The following is a description of a gene set: Human Gene Set: ZNF146_TARGET_GENES studied in species Homo sapiens from publication Yevshin I, Sharipov R, Kolmykov S, Kondrakhin Y, Kolpakov F (PMID 30445619) Genes containing one or more binding sites for (ZNF146) in their promoter regions (TSS -1000,+100 bp) as identified by GTRD version 20.06 ChIP-seq harmonization., and this is the list of marker genes: AGK-DT (NCBI Gene Id 105375538), HTR5A, CCDC18, JPX, NSL1, FAM83C-AS1, ZNF609, CHURC1-FNTB, CCNE1, LINC01349, ZNF579, CHEK2, TOMM7, LINC01886, ATRIP, WRAP53, NME1, RANBP3, TMEM68, TBC1D13 (TBC1 domain family member 13), ITGB1, ITPK1P1, IFNAR1, PLK1, LARGE1 (LARGE xylosyl- and glucuronyltransferase 1), RNU1-52P, TRIAP1, MIR5188, TMEM79, EEF1A1P8, UBE2I (ubiquitin conjugating enzyme E2 I), MIS12, INTS5, RLIG1, TUBD1, ZNF101P1, RPP14, APRT, TSEN54, ALG1 (NCBI Gene Id 56052), VWA8-AS1, DNAJC27, FAM81B, TARS2, ST13P2, MTF2, STRBP, JMJD4, C17orf67, ABCD1, RNU7-24P, APLP2, NLRP5, RNA5SP60, MRPS2, RNVU1-19, CCDC74A, HMGB1, FADS2, ODF2L, MRPS31P5, ALKBH3, COX16, HNRNPA3P3, ZNHIT6, GPS1, CRYM, HSP90AB1, H4C8, YAP1, RPS4XP19, SERP1, SNX12, LINC02953, RPL9P28, ZNF529, RN7SL322P, NDUFB3, RBPMS, RN7SL19P, ZFYVE26, H2AC11, WDR11, KMT5B, GSPT1, MED18, PPP1R14BP5, MTBP, PHIP, PHF19, LINC00917, MRPL27, AURKAIP1, RASL11A, SMARCA1, SCRT1, DPH7, MAST3-AS1, ADGRB3, MT-ATP6, MRPS34, SIRT6, ARHGAP45, SMCO2, CCDC97, NOP56, IGLV4-60, PRPF8, RNU6-131P, ARHGEF2, ENSG00000259362, MCL1, VPS33A, ATP5MC2, TIA1, ZNF540, MTFR1P1, WEE2, SPICP1, GSAP, BORCS8, GSTCD (glutathione S-transferase C-terminal domain containing), ADGRL1, MIR1302-3, GIT1, NACA3P, PLCB2-AS1, PSMD9, RNU7-38P, SMG7-AS1, ASH2L, SEMA7A, AP1G1, CALM1, LTN1, FAM13A, TMEM223, GDI1, TMEM167B-DT, GUCD1, MEF2D, MRPL1 (mitochondrial ribosomal protein L1), HELQ, PGS1, UBP1, MT-RNR1, LIPM, NOP16, CFAP20, PLAGL1, C2orf42, TMCO1, SNAP25-AS1, CNNM1, CYB5D2, MFF-DT, STX16-NPEPL1, HIVEP3, FHL1, ENSG00000247416, PTS (6-pyruvoyltetrahydropterin synthase), SPSB2, HHATL, CLTCL1, ZMPSTE24-DT, BLOC1S1, GBA1, LMAN2, ADAM22, WDR11-DT, GALNT16-AS1, LINC01933, ADAP2, IZUMO4, LZIC, ZNF791, MT-TA (mitochondrially encoded tRNA-Ala (GCN)), TIPRL, ENSG00000232234, SLC3A1, GDI2, WNK3, RNU6-38P, YBEY, RNU6-232P, TCF3, OGFOD1, MRPL21, INTS12, LAMP2, ARPC3P3, CNIH3, TAX1BP1, SNX25P1, CALM1P1, HSPD1P21, TJP3, LINC01719, SNX29P2, RNU6-1059P, TTC3, MITD1, DSTYK, RANBP3-DT, STX18-AS1, ACTMAP, ANAPC2, DNMT3A, AGK, RFC1, PTPRN, RBBP5, MTHFD2L, BBS7, C10orf88, RNU5A-5P, SMPD4P1, ITFG2-AS1, RNU7-27P, DNTTIP1, PIERCE1, TRIM46, MALLP2, MT-ATP8, PGBD5, MACROH2A1, FAM136A, MDH1 (NCBI Gene Id 4190), SPINT1-AS1, RPL36AP18 (NCBI Gene Id 100271328), COX11P1, RYR1, TOP3B, STMP1, SELENOH, SSRP1, ZNF554, BMS1, RPL37, ZNF233, HDGF, C4BPAP2, DCUN1D2-AS, EME2, ZNF181, NOSIP, TSEN15, HERC1, RPS20, SBF2, TAFA2, EXOSC1, SLC33A1, IGDCC4 (immunoglobulin superfamily DCC subclass member 4), SNRNP35, MT-TE, RTTN, CDK1, NOL8, BBX, COPS9, RNU2-31P, ZNF335, TPRX1 (NCBI Gene Id 284355), TLK1, C12orf76, MT-TN, USPL1, CCNL1, TAOK3, CCDC159, CALCRL-AS1, IGHMBP2, CRTC3, LEO1, SCAMP5, HMG20A, SEC22C, FAM227B, SMARCD3, CMKLR1, KPNB1-DT, TSPAN10, ARID1B, COPS7B, RFNG, NOL12, HP1BP3, DCTN5, MIA2, NCAPG2, TM9SF4, ADIPOR1, ANKRD36BP1, AKT2 (NCBI Gene Id 208), PLAC8, EPCIP-AS1, MARCHF8, CCNB1IP1, MRPS31P4, DDR1 (NCBI Gene Id 780), ABCB7, AFG2B, ANKRA2, RBM42, COL12A1, RPL3P2, RN7SL507P, GDF15, STK32A-AS1, WTAP, ZNF131, LINC02050, SNRPCP5, MRPS31, PTPN11, CDIPT, POMT2, TRPV1, NLRP8, LINC02890, EZR, MTREX, CRACD, CEP95, BCAS2P1, MT-TY, HSD17B1-AS1, LINC00396, LINC01411, INTS14, CROCCP2, PSCA, ZCCHC4, NSFL1C, MTMR9, DYNC2I2, PALB2 (partner and localizer of BRCA2), USP30, DUSP7, ZNF410, RNA5SP261, RPS6KB1, RPL5, LINC00869, PPP2R2A, EEF1A2, ZNF569, CMBL, TMEM147, HACE1, CMTR1, EIF1P7, TUBAP7, KMT2B, LRP12, PTPN21, SLC44A1, NEAT1, LINC02436, CAPN2, MT-TC, ERICH6B (NCBI Gene Id 220081), NPM1P9, SMIM8, SYDE1, PHF21A, PFKM, RFXANK, ERCC5 (NCBI Gene Id 2073), UTP15, ENSG00000263011, TSR3, UBA7, RFX3, SNORD4B, DNAH5, POLD1, RN7SKP112, DNM1, SEC13, TENM3, IFNA2, PTP4A1, SRSF4, POP4, RN7SL392P, ACTBP11, PHGDH, ULBP1, KLLN, DNAJC25, VAV1, EIF2D, EMC9, PBX4, TRIP12, SDAD1, RNA5SP232, PEX3, DYNC1I2, DRG2, SNX25, PLAT, USP20, ARL5A, AGTRAP, MIR194-1, NDUFC2-KCTD14, FABP5P15, NME1-NME2, RNU6-27P, UQCC4, USP36, KBTBD4, ABCA8 (NCBI Gene Id 10351), RAF1, LSM5, STK24P1, COQ8B, WDR90, ZSCAN12, BIRC6, PES1P2, BTRC, WASHC5, DTWD1, HINT1P1, LYPLA2P1, RBM28 (NCBI Gene Id 55131), AP3S2, CERNA3, IL23R, TUBA8, GRPEL2P2, PPP1R11, CTNNB1, TMA16, RNU6-312P, ALDOA, PTPN2, SERPINB6, RN7SL47P, RPS2P25, MAPKAPK5-AS1, RBM33-DT, KLHL26, TMEM242-DT, GOLGA3, BEND2, MRPL30, DNASE1L1, TRGV2, BUB3, H3P42, FAHD1, KRT18P68, C18orf21, BRWD1, VEZT, CFAP74, ADGRG4, HEATR1, KRT8P24, HYCC2, FAM89A, RPL37A, CYCSP34, ATP2C2-AS1, ATL3 (atlastin GTPase 3), TRBV21OR9-2, MFSD6, POLR2J3, RUBCN, CD209, ITGB3BP (integrin subunit beta 3 binding protein), HEXIM2-AS1, RN7SKP59, GOSR2, VARS2, POLE4, CTNNBL1 (catenin beta like 1), LINC01804, MRPL55, FGA, TCN1, NDUFA11, NFATC3, CPLX1, RNVU1-6, RPS23P9, EXOSC3, RN7SKP219, CCDC14, NDUFAF2, AP4M1, FA2H, E2F4, NDUFAF1, SF3B6, FBLN7, FKBP7, MT-TS1, SLC22A15, RNU7-148P, PCBP2, LINC01981, MFSD12, TOR1AIP1, OTUB2, RBM33, PDLIM1P2, CLTC, NPLOC4, SSU72, ZNF689, MARCHF4, TRPC6P10, ZNF561, METTL9, RNU6-1009P, PSMD8, COL4A5, LMX1B-DT, CHURC1, FAM149B1, ATP5PF, TRBV21-1, ZBBX, HTR3D, UBE2D3, ABHD13, PKM, SNRPA, SEL1L3, GABPA, ENSG00000212187, TUT1, PEPD, MCM7, RNU6-901P, TVP23B, FBXO22, COQ4, TUBGCP3 (NCBI Gene Id 10426), WDR25 (WD repeat domain 25), VPS25, SNX29P1, MRAS, GMDS, CHADL, CD4, FRYL, KMT2A, TUBB2B, NKAPP1, CCAR2, COPS6, WDR31, LGALS13, SNHG17, VN1R105P, CPB2-AS1, TRGV4, NOPCHAP1, SMG9, PDE6D, CCT6B, PAFAH2, ELAC1, COL4A6, RPL32P28, TMEM248, HIRA, RALB, SF3A3, SNHG11, SERPINI1, PSMD11, PPP1R9A-AS1, ATP5F1B, LINC02960, ITGAL, STEEP1, NUP43, EIF6, DNAJC11, LGALS14, KRTCAP2, PDE4C, RCOR1 (NCBI Gene Id 23186), DZANK1, TRMT112P7, ZNF518A, PPP5D1P, DNM2 (NCBI Gene Id 338330), UBE2D3-AS1, EIF2B4, LYPLAL1, ZZEF1, HEXIM1, LINC01587, NDUFS3, ASMTL, PROCA1, LINC02341, ADGRE2, PIGL, NUP160, ZBTB45, POLR2C, NOXA1, DDX55, SNORD54, XIST, IGF1R, OR7A18P, THRB-IT1, PFDN4, SEMA6A, ABCA9-AS1, PPP4R1, ZMAT2, CSRP2P2, IFT56, RNVU1-27 (NCBI Gene Id 124904621), PPIP5K2 (NCBI Gene Id 23262), FERRY3, OSBP2, ERBB4, CYP4F3, KPNB1, EIF1AD, MED9, PLIN1, GPC6, STRA6, PPIAP45, ZMYM6, RALBP1, COQ8A, NFIB, PPT1, NAGPA, TUBG2, RN7SL328P, CYCSP27, MIR606, RPS16, FAM110A, DERL2, EXD2, SMIM23, PPP1R37, CTNNA2, STOML2, NEURL2 (NCBI Gene Id 140825), ERMARD, TRDMT1, BNIP1, ZNF106, MCM3AP, CPLX2, IPO4, LINC02345, DNAJC25-GNG10, MEF2A, CBFB, RNU6-1106P, TATDN3, LSR, RTN4, EOLA1-DT, KCTD21, TARBP1, ZNF236-DT, CDC42SE1, ATG4AP1, HNRNPA1P24, KDM5A, LINC02332, RNF213-AS1, GLUD1P3, MTCO3P12, DPEP1, MRPL40, MIR548AA2, LINC02909, SSBP1, RNA5SP491, SUGCT, NSD2, TOB2, AJUBA-DT, KDM5C, COMMD4, ADIPOR2, STX18, KCTD5 (NCBI Gene Id 91152), RBL1, DCBLD2 (NCBI Gene Id 131566), TMCO1-AS1, ZDHHC16, ING4, MRPL13, TMEM26, UBE2D2, SUDS3, ARSB, ZMPSTE24, RPS7, CRX, ITGA7, VWA8, CENPP, JRK, LCE1C, DNAJC13, CFAP410, FAM167A-AS1, REXO4, SLC25A45, ENSG00000232995, SLC25A24, MAML3, BCL7B, EPB41L4A-AS1, RNU6-59P, COMMD2, CASKIN2, ANO3, ENSG00000252923, RNU6-944P, HNRNPA1P25, GABPB1-AS1, ENTPD1-AS1, ANGEL1, RPL7P24, MIR6514, LHX3, LINC01068, MT-TT, NPM1P50, ARHGEF28, RPL31P61, GTF3C3, OSTM1, MIA3, CENPB, BORCS8-MEF2B, ZBTB20 (NCBI Gene Id 26137), KDM3A, HAGH, ZNF561-AS1, LRRC59, DDX5, RNA5SP399, TMEM41A, DNM1P38, RNVU1-3 (NCBI Gene Id 101954274), SNORA14B, MIR1538, ZNF165 (zinc finger protein 165), RNA5SP91, EDC3, SNRNP27, SNRPD3, POLR3F, PCLAF, RAD51AP1, PPM1N, HEXA, ZWILCH, EFCAB7, SMG1P1, HEMGN, EIF3E, RILPL2, MBD6, SPOCD1, LTBP4, HSDL2-AS1, LINC00868, PDIA5, ARID1A, MED4, TMEM144, SLC36A4, ITGB1-DT (NCBI Gene Id 101929475), C17orf75, DPY19L4, CDCA4P2, UBB, RPL12P21, DCTPP1, ARHGEF1, TLCD3B, HOXD8 (NCBI Gene Id 56182), ADCY10, BBS1, TBC1D19, STX16, ZBTB21, RN7SL819P, SEC16B, GEMIN8P4, SLC4A1AP, ATP2C1, DEUP1, LINC01201, PRCP, CCNI, RGS5, SNAP23, RNU6-294P, CDK5RAP1, TAB2, NMNAT1, TACO1, OR7E101P, ANKRD24, VCL, TMEM82, TMEM263, CCDC77, ENSG00000239008, SEMA4B, ADPGK, FUT5, DLG1, LAMP1, VPS51, CDCA2, DUS1L, RPL31P33, ENSG00000222966, CDIPTOSP, LRRC37A5P, CCDC88A, SSBP2, PEAK1, OR7E111P, TIMM22, TRIP4, ACSM3, GPR42, SNRPE, LINC02613, SSNA1, ISLR2, TREX2, TEFM, GNPTG (NCBI Gene Id 84572), TTI2, NCSTN, TBCB, MIR7-3HG, ECE2, ZSCAN9, GTF3C5, CALM2, OSMR-DT, PCID2, OGT, YKT6, ALG14, OR52E6, MRPL44, PFN2, RPA2P2, SCN8A, BRF2, MIR3117, RALY, ENSG00000231252, CLCC1, WDR36, LINC01691, NUDCD1, FAM76B, FOXJ3, SLC39A3, ZNRF1, PGK1, ANKRD40, GABPB1, HEXIM2, TMEM147-AS1, PDCD6IP, SLC50A1, SUCLG2-DT, ISCA1P2, RPL27, HTD2, ENSG00000248161, MT-TK, TUBGCP4, LRP6, LINC00431, GUSBP1, FAH, TRIAP1P1, CTSA, ANKS4B, WTIP, NCAM1, ASB6, RABEP1, UNC5B, NCBP3, PSORS1C1, BBS2, MKRN2, OSMR, ZNF302, GATM, TSBP1, ACSL1, CELF6, RPS26, SLC24A1, MLEC, SUPT7L, LINC01596, FBXO36, HNRNPL, MTND5P11, LHFPL5, BANF1, EIF2S2P6, PRDX1, ADAM18, FBXW8, VMAC, SENP8, GRB2, PDE8A, SENP1, FAM228B, LNPK, EDC4, MAPK8IP2, GLRA1, ACTL6B (actin like 6B), KNL1, SLC10A7, EWSR1, SMG8, TLE2, HASPIN, PRODH2, NDUFS7, DYRK4, RPL4, MFHAS1, TFDP1, SMG5, ZC3H13, GTF2B, LMX1B, RNF34, FEZF1-AS1, LIN9, SNORA13, EOLA1, CYP4Z1, KIAA2013 (KIAA2013), B4GALT7, MCAT, RNA5SP117, CDR2, SLC35A3, SNX15, CA11, ZNF570, DPY19L3, C9orf78, RPS2P4, TMEM230, STMN3, CYP2R1 (NCBI Gene Id 79445), PPIL3 (NCBI Gene Id 53938), POLR2I, MAN2C1, CTC1, ANAPC5, EXD3, ENPP3, UBE2B, KCTD9, E4F1, PLXDC1, METTL15 (methyltransferase 15, mitochondrial 12S rRNA N4-cytidine), FEZF1, RABEP2, PDLIM1P3, STAG1, STK10, PHF21B (PHD finger protein 21B), SP3, SUPT5H, SECISBP2L, PLEKHM3, DNAJC27-AS1, SKP2P1, RAB3GAP1, RPL6, KLHDC1, FRA10AC1, ANO8, TREML5P, PTGR2, RNVU1-15, SUSD5, ENSG00000239041, ZMYM4, SAR1B, ZNF529-AS1, UQCC6, ATAD2, RNA5SP190, ZNF217, WT1, CALM3, ENDOV (endonuclease V), ITGAE (integrin subunit alpha E), DPY19L3-DT, KRT8P11, MIR764, TTN-AS1, BTBD1, OR7E104P, PROX1-AS1, WFDC3, C2CD5, DOCK5, RPS23P10, PRSS27, PEMT, ACOXL, MNAT1, ANP32E, AAR2, CSGALNACT2P1, EGR4, MBTPS2, SPSB1, RPL21P30, DMAP1, PDCD6P1, BAAT, GEMIN6, WDPCP, WEE2-AS1, ALPI, CCDC125, RPL37A-DT, TOMM20, RPL22, MUC20-OT1 (MUC20 overlapping transcript), BDKRB2, OLIG1, AAK1, MTR, COG2, ARL2BPP1, GTF2IP22, MT-ND6, SRSF7, IL2RB, RPL29, PSTK, CCDC69, ADAT2, MTIF2, ZNF780A, SRSF1, PRR15-DT, UBR2, KLHL25, SPRED1, RPSAP14, GGACT, KRT224P, IP6K1, ANKRD12, CDKL3, ZC3H6, RCOR2, UBC, NDUFC2, POLI, MPLKIP, DCP1A (NCBI Gene Id 55802), DOCK10, SLX9, RPS26P56, EIF4A2, PDXK, MED23, MASP1, CLEC4M, KCNH6, H2BC11, RNU6-393P, OR5K2 (olfactory receptor family 5 subfamily K member 2), TPTE2P5, TAF3, CIZ1, PTK2 (protein tyrosine kinase 2), YIF1A, FYTTD1, FREM2, CCAR1, PML, TMEM44, PIM3, CUL4A, SIGLEC16 (NCBI Gene Id 646039), PAXBP1, PAIP1, CDK14, EEF1DP2, ENSG00000212182, ATXN2L, CKB, TMCC2, NFAT5, RNF14P4, EZH2, IMPDH1P4 (inosine monophosphate dehydrogenase 1 pseudogene 4, NCBI Gene Id 139334), JCHAIN, GTPBP3, CMTM7, SPACA3, ASAH2B, ZKSCAN2, RAB3IP, KIF2A, ECD, MOB3A, SNX17, JMJD1C, TGS1, MTCO1P2, NUDT19P3, RNU6-19P, NSMCE2, SAT1, SNRPCP14, RFX7, NUF2, ATG101 (NCBI Gene Id 95005), STK36, PRRG2, ARHGEF12, STEAP1B, RBPMS2P1, EEFSEC, BMS1P4, TMEM167B, RPL29P12, HDDC3, ANXA2, BHMT2 (betaine--homocysteine S-methyltransferase 2), TUSC8, NEK4, GTF2H4, MEGF10, HEXA-AS1, CDH26, BMS1P4-AGAP5, CAPZA2, DDIT4, MIR7-3, RNA5SP433, TIPINP1, LSG1, GHITM (growth hormone inducible transmembrane protein), ASCC1, SMARCD2 (SWI/SNF related, matrix associated, actin dependent regulator of chromatin, subfamily d, member 2), ARMCX5, ZER1, MTIF2P1, STAT6, RARS1, COQ3, GABARAP, KDM1A, METAP2 (methionyl aminopeptidase 2), DYNLT2 (NCBI Gene Id 6991), PDXDC1, GABPB2, NCOA1, ZNF490 (NCBI Gene Id 57474), GIN1, GNB2, TBCD, PTEN, SLC13A3, APOL2, FAM98B, PDLIM1P4, PRKCH, TMEM101, SNRPCP11, LAIR2, RN7SL293P, SNORD55, PFAS, FAAP100, RPS3AP51, ZNF76, N4BP3, NEK7, GATC, AJUBA, RASSF8, SRSF3P1, SRRM3, ZNF558, ELAVL2, CAMKV, AHCYP2, ZNF786, COPS3, SPICP5, PSMB6, BARHL1, WDR24, SYCP2, FGD6, HNRNPA1P26, TOB2P1, ARGFXP1, ZNF326, LAIR1, SP9, SMG7, EVI2B, MSR1, MT-TF, KLRF1, DUTP4, GALNT7, LIG4, ALG3, VDAC2P2, LINC02104, AKR1C7P, LINC01547, AKAP6, SNAP47, NFE2L2, TMEM242, SLC6A1, SSU72-AS1, MFF, TRUB2, SPOCK1, TSC1, DAD1, POLR3E, GGTA1, TBPL1P1, SETD1A, CENPU, MST1P2, LYSET, CST7, MBD3L1, SNRNP70, PCAT6, RNU6-33P, MRPS18C, IFTAP, SLC35E1, CYB5R4, SNORD59A, NCOA4, GFI1B, CLCN7, SLC25A36, TBL3, MIR548H2, SEPTIN7P7, ZSCAN25, GAPDHP31, ATP6AP1L, ARMC10, MAPKAPK5, SLAMF6, CCNG2, EEF1A1P18 (NCBI Gene Id 100887747)